The following is a description of a gene set: Human Gene Set: GOBP_POSITIVE_REGULATION_OF_TRANSPORTER_ACTIVITY Any process that activates or increases the activity of a transporter. species: Homo sapiens, and this is the list of marker genes: CTSS, SGK2 (NCBI Gene Id 51178), PRKCD, LRRC52, SGK1, TESC, STIM1, EDN1, CRACR2A, TRPC6, FGF13, CHP1, ACTN4, ASPH, GAL, COX17, JPH2, VMP1, CACNB3, LRRC26, STIMATE, ATP2A1, STIM2, LRRC55, SCN1B, STAC2, EDNRA (NCBI Gene Id 1909), TCAF1, WNK2 (NCBI Gene Id 65268), SYNGR3, STAC (SH3 and cysteine rich domain), WNK3, CASQ1, CFTR, HTT, STAC3, HAP1, LRRC38, GALR2, NIPSNAP2, TMSB4X, ATPSCKMT, ACTN2